The following is a description of a gene set: from publication Calvet L, Geoerger B, Regairaz M, Opolon P, Machet L, Morizet J, Joseph JM, Elie N, Vassal G (PMID 16501609) Genes down-regulated in neuroblastoma xenografts: resistant vs those that reverted to be sensitive to the topoisomerase inhibitor irinotecan. studied in species Homo sapiens Human Gene Set: CALVET_IRINOTECAN_SENSITIVE_VS_REVERTED_DN In vivo neuroblastoma (NB) xenograft model, resistant to the DNA-topoisomerase I inhibitor irinotecan (CPT-11), has been established to study resistance mechanisms acquired in a therapeutic setting. Common mechanisms of resistance were not involved in this resistance. Thus, we compared the gene expression profiles of sensitive, resistant, and reverted tumors using cDNA expression arrays. Expression of selected transcripts was confirmed by quantitative real-time PCR. We found that pleiotrophin (PTN), a heparin-binding growth factor, was the only gene significantly affected: PTN gene expression was downregulated in all resistant tumors (8-14-fold) as compared to sensitive tumors, and was increased (2-4-fold) in all reverted tumors as compared to resistant tumors. PTN thus appeared to be a likely candidate gene associated with resistance to CPT-11 in this in vivo model. To investigate the direct implication of PTN in NB, we transfected two NB cell lines with RNA interferences in order to silence PTN. PTN failed to demonstrate implication in resistance to CPT-11 in vitro but could influence sensitivity to CPT-11 exclusively through an in vivo mechanism. Indeed, vasculature was significantly enhanced in resistant NB xenografts compared to sensitive and reverted xenografts, and we suggest that PTN is acting in our resistant in vivo NB model as an angiostatic factor., and this is the list of marker genes: RHOB, CDH5, PTN, PCNA, HOXD3